The following is a description of a gene set: Genes positively correlated with amplifications of MYC in SCLC (small cell lung cancer) cell lines. species: Homo sapiens Human Gene Set: KIM_MYC_AMPLIFICATION_TARGETS_UP DNA amplifications and deletions frequently contribute to the development and progression of lung cancer. To identify such novel alterations in small cell lung cancer (SCLC), we performed comparative genomic hybridization on a set of 24 SCLC cell lines, using cDNA microarrays representing approximately 22,000 human genes (providing an average mapping resolution of <70 kb). We identified localized DNA amplifications corresponding to oncogenes known to be amplified in SCLC, including MYC (8q24), MYCN (2p24) and MYCL1 (1p34). Additional highly localized DNA amplifications suggested candidate oncogenes not previously identified as amplified in SCLC, including the antiapoptotic genes TNFRSF4 (1p36), DAD1 (14q11), BCL2L1 (20q11) and BCL2L2 (14q11). Likewise, newly discovered PCR-validated homozygous deletions suggested candidate tumor-suppressor genes, including the proapoptotic genes MAPK10 (4q21) and TNFRSF6 (10q23). To characterize the effect of DNA amplification on gene expression patterns, we performed expression profiling using the same microarray platform. Among our findings, we identified sets of genes whose expression correlated with MYC, MYCN or MYCL1 amplification, with surprisingly little overlap among gene sets. While both MYC and MYCN amplification were associated with increased and decreased expression of known MYC upregulated and downregulated targets, respectively, MYCL1 amplification was associated only with the latter. Our findings support a role of altered apoptotic balance in the pathogenesis of SCLC, and suggest that MYC family genes might affect oncogenesis through distinct sets of targets, in particular implicating the importance of transcriptional repression. from publication Kim YH, Girard L, Giacomini CP, Wang P, Hernandez-Boussard T, Tibshirani R, Minna JD, Pollack JR (PMID 16116477), and this is the list of marker genes: SUCLG1, CYP7B1, IRF2, MRPL13, EBPL, PVT1, NMNAT2, NALF2, COX6B1, COX7B, PDHA1, C1QTNF1, FAM216A, ALOX5AP, NEFL, SPINK5 (NCBI Gene Id 50962), LNP1 (leukemia NUP98 fusion partner 1), MYC, RPS23, NIP7, KCNQ3, CD163L1, PARK7, BLMH, CITED4, AKAP13, NEUROD4, CEP152, VRK1, LRRC28, TMEM38B, SLC16A1, MIR17HG, LTF, CNTN1, ITGA4, RAB3C, PHKA1, HPRT1, RPL12, EEF2K, IDH3A, TMEM64, GATD3, SELENOI, NEK3, GPATCH4, ETFA, SSBP1, DAG1, CCL26, PRRG1, AP5M1, HS3ST4, PFAS, RPL5, FUT4, GOT2, RHOB, RGS10, RIOX2, DRG1 (NCBI Gene Id 4733), SLC19A2, SACS, MRPS33, AQP3, KLHL29, OLIG2, RABEPK, WDR3, ANGPTL2, RRP9, PPAT, HSD17B12, RAB8B, GALK2, SHC3, PRDX6, DDX21, DLEU1, LDHB, XPC, RIN2, TIPIN, EPB41L4B, SLC39A10, PCLAF, LYAR, ADARB1, LRPPRC, MYCBP2, LYRM1, RPL11, ACLY, EIF2S2, NDUFS1 (NCBI Gene Id 55372), XIST, PGRMC1, NHLH1, AKR1B1, CDKAL1, RPS15A, RRP1B, CA12, NME2, NME1, HSPD1, LAMB1, TTC7B, PGM2, NCL, PAICS, FARSB, EEF1E1, RSL24D1, RPS27L, MAK16, ANKRD55, PNP, MRPS34, VEGFD, MCC, ABCC3, KARS1, EIF3J, CTNNAL1, LYPLA1, NUDT11, DHX33, PRMT6, NOB1, ATP2B2, LRRK2, ODC1, PDLIM3, PRPS1, GATM, MRPS2, GAB1, UTP4, PSMG1, DAP3, DGKZ, FAM241A, CX3CR1 (C-X3-C motif chemokine receptor 1), SEMA6A, ALDH3A2, ST6GALNAC2, FAM89A, POLR3K, EGFLAM, MXI1, CHGB, SLC25A39, NOP56, FBL, RPS4X, PUS7, NAA30, PEMT, MRPL50, ENO1, SLC6A15, RAPGEF5, LEO1, NRP2, CLIP4, PDPN, DKC1, DDX18, SLC7A5P1, DACH1, MAGI1, AGL, ARHGEF6, MRPL36, ARL6IP5, MCTS1, MIR503HG, NDUFAF2, FASTKD1, NEFM, MRPS23, GPI, PPP1R17, SLC25A5, IGSF11, CHN1, CYCS, PCOLCE2, SGCD, DIPK1B (divergent protein kinase domain 1B), ATP5F1B, RPSA, AIFM1, LAT, NIFK, TRMT10C, RPL18A, WDR41, SSB, KCNS1